The following is a description of a gene set: studied in species Homo sapiens Protein avoidance Human Gene Set: HP_PROTEIN_AVOIDANCE, and this is the list of marker genes: OTC, ASL, ASS1, SLC25A15, CPS1, SLC7A7